Given this list of marker genes Cd59a, Cnmd, Mmrn1, Emilin1, Pdcd6, Mmrn2, Ptpn1, Cadm4, Hgs, Dab2ip, Nedd4, Hhex, Epn2 (NCBI Gene Id 78669), here is a description of the gene set: Any process that stops, prevents, or reduces the frequency, rate or extent of vascular endothelial growth factor receptor signaling pathway activity. Mouse Gene Set: GOBP_NEGATIVE_REGULATION_OF_VASCULAR_ENDOTHELIAL_GROWTH_FACTOR_RECEPTOR_SIGNALING_PATHWAY studied in species Mus musculus